Given this list of marker genes Emc6, Vars1, Lars1, Peli1, Noc2l, Taf10 (NCBI Gene Id 24075), Pfn1, Ppp3cc, Sars1 (seryl-tRNA synthetase 1), Eno1, Uchl3, Bst2, Fbl, Ppa1, Sh3bp5, Ndufb4, Apex1, Tspan9, Inpp4b, Eif3c, Hint1, Srsf2, Gtpbp4, Lyst, Jund, Eif5a, Psme1, Timm9, Nars1, Hspa9, Wdr46, Mif, Pla2g12a, Psme2, Bcl11b, Nop56, Mars1, Bax, Anp32b, Ncl, Snrpf, Psmb5, Nolc1, Cst7, Uqcrq, Ranbp1, Ucp2, Rad23a, Cnp, Txn2, Mitd1, Park7, Cycs, Mybbp1a, Wdr43, Snrpd1, Csk, Cyth1, Tomm5, Rnaset2a, Bcl2 (NCBI Gene Id 98734), Pole4, Ppp1r14b, Cyfip2 (cytoplasmic FMR1 interacting protein 2), H2az1, Foxn3, Tuba4a, Cct2, Erh, Pa2g4, Psmb9, Uqcc5, Tuba1b, Nme1, Mettl1, Mrpl20, Chchd1, Ubl3, Cdca7, Galk1, Socs1, Cct3, Uvrag, Gar1, Timm13, Cct8, Mrps14, Nhp2, Cdk4, Eef1e1, Surf2, Slfn1 (NCBI Gene Id 20555), Cdk6, Oxct1 (3-oxoacid CoA transferase 1), Dkc1, Ran, Trat1, Suz12, Impdh2, Cct7 (chaperonin containing TCP1 subunit 7, NCBI Gene Id 12468), Cct5, Ptma, Pdap1, Aars1, Eif4a3, Snx2, Hspd1, Lsm7, Eif4a1, Mri1, Nop58, Ddx39a, Prmt1, Banf1, Ncoa3, Cish, Rasgrp1, Mthfd2, Larp1, Gnl3, Ddx18, Yars1, Serbp1, Eif2s2, Trib2, Tcof1, Ndufc2, Mrpl57, Igfbp4, Cars1, Cfl1, Slc25a5, Als2cl, Dusp10, Uqcc2, Set, Atp5mc1, Ddx21, Hypk, Shmt2, Wdr83os, Sft2d2, Psph, Rflnb, Dnajc7, Atp5f1b, Il4ra, Ccnd2, Mbd2, C1qbp, Arl4c, Rexo2, Psma7, Srm, Treml2, Mrpl23, Tmie, Phb1, Iars1, Ndufs4, Slfn2, Fabp5, Lsm8, Pdcd4, Mia2, Sdhb, Phgdh, Npm3, P2ry10, H2-DMa, Mrto4 (mRNA turnover 4, ribosome maturation factor), Nsmce1, Glipr2, Elf1, Elob, Timm10, Npm1, here is a description of the gene set: Genes positively differentially expressed in cell type: CD4+ T cell upon treatment with cytokine: IL-4 in mouse lymph nodes in vivo. species: Mus musculus Cytokines mediate cell-cell communication in the immune system and represent important therapeutic targets. A myriad of studies have highlighted their central role in immune function, yet we lack a global view of the cellular responses of each immune cell type to each cytokine. To address this gap, the authors created the Immune Dictionary, a compendium of single-cell transcriptomic profiles of more than 17 immune cell types in response to each of 86 cytokines (>1,400 cytokine-cell type combinations) in mouse lymph nodes in vivo. A cytokine-centric view of the dictionary revealed that most cytokines induce highly cell-type-specific responses. For example, the inflammatory cytokine interleukin-1β induces distinct gene programmes in almost every cell type. A cell-type-centric view of the dictionary identified more than 66 cytokine-driven cellular polarization states across immune cell types, including previously uncharacterized states such as an interleukin-18-induced polyfunctional natural killer cell state. Mouse Gene Set: CUI_T_CELL_CD4_IL4_RESPONSE_UP from publication Cui A, Huang T, Li S, Ma A, Pérez JL, Sander C, Keskin DB, Wu CJ, Fraenkel E, Hacohen N (PMID 38057668)